Given this list of marker genes BUB1, SEC24C, FIG4, SMG9, PTPRF, NOTCH2, NDUFB11, HYMAI, HCCS, ELN, DOCK7, DPYD, CDH11, PIGL, KMT2D, CEP152, CREBBP, PIGB, CRKL, UFD1, SLC26A2, WWOX, PHF6 (PHD finger protein 6), HDAC8, RECQL, ATR, ESCO2, WARS1, LAS1L, HIRA, HBA1, FLI1, DNA2, KDM6A, COX7B, HS2ST1, HRAS, PIGQ, BRAF, HMX1, PGM2L1, ARVCF, RBM10, IL1RAPL1, SIN3A, RERE, WBP4, CUL4B, DHCR24, CHD7, TRIP12, HBA2, B4GALT7, ZEB2, TBX1, RNU4-2, RBBP8, PLAGL1, MGAT2, COL3A1, EIF2S3, SMARCD1, COMT, ZFX, POLR3A, WDR4, SLC35C1, PLXNA1, SLC32A1, TMEM94, MAN2C1, FN1, EFTUD2, EP300, MLXIPL, VPS53, SRRM2, SMS, KCTD1, FGFR2, OTUD5, PRR12, NUP85 (nucleoporin 85), PHIP, VPS13B, PIGA (phosphatidylinositol glycan anchor biosynthesis class A), EHMT1, TRAIP, GPC3, SMOC1, UFC1 (NCBI Gene Id 51506), SCARF2, CENPE, BCR, POR, SEMA3E, SPEN, EBF3, HIVEP2, AHDC1, BMP4, MAPK1, COL2A1, GP1BB, ATRIP, ZMYM2, ABHD5, RAC1, TBL1XR1, CAPRIN1, HNRNPH1, ZNF407, SMAD4, GRIA3, JMJD1C, KAT6A, PGAP3, MED25, BICRA, NSD2, PIK3CA, GJA1, PIGY, CNTNAP2 (NCBI Gene Id 26047), TPRKB, FGD1, PLK4, RREB1, PCNT (NCBI Gene Id 9346), KMT2C, UGDH, CDC42BPB, NR2F1, TWIST1, CDC6, GPC4, SETBP1, KMT2B, MAPRE2, RDH11, ERI1, here is a description of the gene set: Human Gene Set: HP_ABNORMAL_EARLOBE_MORPHOLOGY Abnormal earlobe morphology An abnormality of the lobule of pinna. species: Homo sapiens